Given this list of marker genes Junb, Jund, Cenpa, Ubc, Klf6, Dusp1, Btg2, S100a6, Fos (FBJ osteosarcoma oncogene), Rhob, Dusp5, here is a description of the gene set: from publication Cui A, Huang T, Li S, Ma A, Pérez JL, Sander C, Keskin DB, Wu CJ, Fraenkel E, Hacohen N (PMID 38057668) species: Mus musculus Cytokines mediate cell-cell communication in the immune system and represent important therapeutic targets. A myriad of studies have highlighted their central role in immune function, yet we lack a global view of the cellular responses of each immune cell type to each cytokine. To address this gap, the authors created the Immune Dictionary, a compendium of single-cell transcriptomic profiles of more than 17 immune cell types in response to each of 86 cytokines (>1,400 cytokine-cell type combinations) in mouse lymph nodes in vivo. A cytokine-centric view of the dictionary revealed that most cytokines induce highly cell-type-specific responses. For example, the inflammatory cytokine interleukin-1β induces distinct gene programmes in almost every cell type. A cell-type-centric view of the dictionary identified more than 66 cytokine-driven cellular polarization states across immune cell types, including previously uncharacterized states such as an interleukin-18-induced polyfunctional natural killer cell state. Genes negatively differentially expressed in cell type: γδ T cell upon treatment with cytokine: APRIL in mouse lymph nodes in vivo. Mouse Gene Set: CUI_T_CELL_GD_APRIL_RESPONSE_DN